The following is a description of a gene set: studied in species Mus musculus A small, subcellular membrane-bounded vesicle containing pigment and/or pigment precursor molecules. Pigment granule biogenesis is poorly understood, as pigment granules are derived from multiple sources including the endoplasmic reticulum, coated vesicles, lysosomes, and endosomes. Mouse Gene Set: GOCC_PIGMENT_GRANULE, and this is the list of marker genes: Nap1l1, Slc24a5, Gna13, Cnp, Slc3a2, Slc1a4, Itgb3, Ncstn, Ankrd27 (ankyrin repeat domain 27), Ahcy, Ganab, Lamp1, Cltc, Capg, Gpnmb, Bace2 (NCBI Gene Id 68803), Rab29, Myo7a, Atp6v0a1, Hsp90b1, Rab5a, Rab2a, Rab27a, Canx, Anxa6, Tpcn2, Atp6v1b2, Abcb6, Sdcbp, Pdia6, Slc45a2, Ppib, Mlana, Pdia4, Myo5a (NCBI Gene Id 57374), Calu, Tyr, Rab1a, P4hb, Anxa2, Rab32, Atp7a, Syngr1, Ran, Tfrc, Snd1, Dct, Rab38, Atp6v1g2, Oca2, Trpv2 (transient receptor potential cation channel, subfamily V, member 2), Mreg, Tyrp1, Myh11, Myrip, Tmem33, Stx3, Ctsd, Serpinf1, Fasn, Th, Rab5c, Sec22b, Sytl2, Ywhab, Pmel, Atp1b3, Mfsd12, Flot1, Ctsb, Apoe, Rab5b, Rab17, Pdcd6ip, Ctns, Stom, Anxa11, Dtnbp1, Ggh, Ywhae, Rab9, Slc1a5, Tpp1, Mlph, Itgb1, Erp29, Hps4, Gpr143, Sgsm2, Dnajc5, Hspa8, Pdia3, Hspa5, Mmp14 (matrix metallopeptidase 14 (membrane-inserted)), Atp1a1, Rab7 (RAB7, member RAS oncogene family), Sypl1, Rab27b, Cd63, Ywhaz, Rab35, Hsp90ab1, Hsp90aa1, Tmed10, Rac1, Gchfr, Cct4, Sytl1